Given this list of marker genes SVIP, APOB, SYVN1, TTYH1, GABARAP, FTCD, RYR2, CASQ1, PGRMC1, HYOU1, RYR3, PSEN1, AQP8, HSD3B2, SLCO1B3-SLCO1B7, NAPEPLD, RPL10, SLMAP, ERP29, GBA2, TH, DMTN, CALR, HSP90B1, RYR1, HSD3B1, PPIB, JPH4, STX17, here is a description of the gene set: species: Homo sapiens Human Gene Set: GOCC_SMOOTH_ENDOPLASMIC_RETICULUM The smooth endoplasmic reticulum (smooth ER or SER) has no ribosomes attached to it. The smooth ER is the recipient of the proteins synthesized in the rough ER. Those proteins to be exported are passed to the Golgi complex, the resident proteins are returned to the rough ER and the lysosomal proteins after phosphorylation of their mannose residues are passed to the lysosomes. Glycosylation of the glycoproteins also continues. The smooth ER is the site of synthesis of lipids, including the phospholipids. The membranes of the smooth ER also contain enzymes that catalyze a series of reactions to detoxify both lipid-soluble drugs and harmful products of metabolism. Large quantities of certain compounds such as phenobarbital cause an increase in the amount of the smooth ER.